The following is a description of a gene set: Genes down-regulated in comparison of peripheral blood mononuclear cells (PBMC) from healthy donors versus PBMCs from patients with type 1 diabetes at 1 month after the diagnosis. species: Homo sapiens Objective: We hypothesized that type 1 diabetes (T1D) is accompanied by changes in gene expression in peripheral blood mononuclear cells (PBMCs) due to dysregulation of adaptive and innate immunity, counterregulatory responses to immune dysregulation, insulin deficiency and hyperglycemia. Research Design and Methods: Microarray analysis was performed on PBMCs from 43 patients with newly diagnosed T1D, 12 patients with newly diagnosed type 2 diabetes (T2D) and 24 healthy controls. One and four month follow-up samples were obtained from 20 of the T1D patients. Results: Microarray analysis identified genes differing in expression between newlydiagnosed T1D patients and controls at a false discovery rate of 0.05. Changes in expression of interleukin-1β (IL1B), early growth response gene 3 (EGR3), and prostaglandin-endoperoxide synthase 2 (PTGS2) resolved within four months of insulin therapy and were also observed in T2D suggesting that they resulted from hyperglycemia. With use of a knowledge base, 81/genes could be placed within a network of interrelated genes with predicted functions including apoptosis and cell proliferation. IL1B and the MYC oncogene were the most highly-connected genes in the network. IL1B was highly overexpressed in both T1D and T2D, whereas MYC was dysregulated only in T1D. Conclusion: T1D and T2D likely share a final common pathway for beta cell dysfunction that includes secretion of interleukin-1β and prostaglandins by immune effector cells, exacerbating existing beta cell dysfunction, and causing further hyperglycemia. The results identify several targets for disease-modifying therapy of diabetes and potential biomarkers for monitoring treatment efficacy. Human Gene Set: GSE9006_HEALTHY_VS_TYPE_1_DIABETES_PBMC_1MONTH_POST_DX_DN from publication Kaizer EC, Glaser CL, Chaussabel D, Banchereau J, Pascual V, White PC (PMID 17595242), and this is the list of marker genes: PNPLA4, DLX2, ALX1, ATXN3L, PEX5L, ZNF223, REXO2, GIMAP5, CBFA2T2, TNFSF18, BICD1, RPGR, SRPK2 (NCBI Gene Id 6733), SIT1, EXD2, MUS81, MYL10, MTHFS, PCBP4, RNF167, LIPE, CD82, CCDC51, CD248 (NCBI Gene Id 57124), UBAP1, CIITA, CBY1, SUOX, RALGPS1, LENEP, ZNF629, TIMM8A, KLF7, PRB4, KPTN, REG1CP, PIP5K1A, SEPTIN9, INPP5E, BOLA1, H2BC13, CRYGD, SKP2, FGA, RTP4, RNF25, DHX32, IL11 (interleukin 11), ERF, TRIM2, PUS3, ATAT1, LBHD1, BBC3, RPS16 (ribosomal protein S16), PRB3, PIWIL1, TAFAZZIN, EGR3, KEL, CHTOP, ACTN2, NALF2, ZNF692, KCNMA1, TIGD6, PCDH7, ADSL, HIVEP2, DST, FMO6P, HSPB7, SLC39A1, JAKMIP2 (janus kinase and microtubule interacting protein 2), LRRC8E, EPOR, FAM111A, C11orf16, DARS2, B4GALT4, KRT4, EIF5B, B4GALT7, DGCR11, KLHL22, TRIM62, CCDC93, RBMX2, VPS52, GULP1, CCR7, PDPK1, FUT7, RGS5, GTF3C2, ING4, CCR1, RNF113A, LRRC75B, ZNF37BP, CPN2, BRD7P3, EEF2KMT, CDKN2C, GFOD2, YIF1B, CNTNAP1, AQP6 (NCBI Gene Id 363), DDX6, BACE1, GMFG, HPCA, F2, CENPI, ALLC, PRELID3A, ZSCAN5A, CLASRP, C3orf18, NCKAP1L, EGR2, TEK, TGFB3, TMEM223, ZNF778, RABIF, WDR5B, DIS3, TMEM104, RABEPK, MRPL17, NOP2, PLEKHA1, MAP3K19, CYREN, ABCC10, HSPA1L, CYP2A13 (NCBI Gene Id 95745), TCTN1, SPSB1, PCSK2, CYP4F12, SLC12A5, SLC19A4P, GOLGA2P5, ANKZF1, PLCG1, NOL6, DNAJC28, HMBS, BTN2A1, C11orf24, SLC19A1, TSPAN32, TIMM8B, SNPH, SEMA6C, HDAC7, RXRA, MLYCD, SH2D3C (NCBI Gene Id 10044), IL16, ZBTB40, TRAF3, NOMO3, ROBO3, ZKSCAN3, POU3F1, CXCL13, HLA-DRB4, TFG, NFIC, MIR622, C1orf105, COA4, PRSS53, LAMB4, DNMBP, ADGRA2, CASR, FEV, CSRNP2, ZNF654, RUFY3, SMCP, KLHL26, BTNL3, WFDC1, MAP3K20, SNX19, DSCAM, HTR1D, FABP1, NOP10, LINC00652, FAM171A1